Given this list of marker genes RRAD, COMT, AGO2, NCOA3, FIP1L1, SH2D2A, B3GNT2, TOLLIP, AKT2, SRXN1, RRS1, CCL4, ZFPM1, FOS, PROM1, JAK2, STAT5A, CCR1, KCTD12, ATP6V0A2, PSMD11, ST6GALNAC4, ETF1, ELL2, IKZF2, EGR2, ZFP36L1, RDH11, FURIN, RHOQ, TRAF4, ACP3, KLHDC2, AGFG1, PLXND1, ITGB1BP1, OTUD7B, RMDN3, ARHGEF3, COL4A3, GABARAPL1, MTDH, PHLDA1, HCCS, IER2, GGNBP2 (NCBI Gene Id 84160), HMGCR, C9orf85, HNRNPLL, GADD45B, TSPAN5, ZC3H14, PDCD1, E2F5, CMTM3, DNAJB6, IGF1, PRDM1 (PR/SET domain 1), ACTG2 (actin gamma 2, smooth muscle), SLC7A7, RNFT1, NR4A1, NMD3, PPM1A, ITGAV, IL4, IL13, GLI3, TLE3, ZC3H11A, ZC3H12C, ACTR10, KPNA1, CCL1, ROCK2, IRF8, F2R, PIM3, NTMT1 (N-terminal Xaa-Pro-Lys N-methyltransferase 1), MSMO1, TNFSF8, PSMD8, GIMAP4, GCH1, LCP2, SRGN, STS, BCL10, CSF1, SLFN12L, FBXW11, DIP2B, ADRA1B, BTG3, SDCBP, TRAF5, NFKB2, PPP2R2A, CINP, ERF, MAP2K3, SLC4A7, TTC39B, VAPA, KLF13, CCND2, IL10, C1orf43, CHMP4B, TFCP2L1, DNAJC1, CSNK2A2, TGFA, SLC41A1, MYO10, FOSL1, DNAAF5, RXRA (NCBI Gene Id 6256), IL12RB1, ACSL4 (acyl-CoA synthetase long chain family member 4), ATP6V1E1, TMEM68, NFKBIA, NOTCH1, NFATC1, AQP8, TOX4, BCAT1, RPL35, PELI1, NAB2, ADORA2B, ATF3, LAG3, SLC35A4, ZAP70, MRPS2, CUL3, CCL13, FGD3, GOLGA7, GATA3, HSD17B12, CXCL14 (C-X-C motif chemokine ligand 14), ARL6, SPRED2, OSTC, CENPC, ZRSR2, RYR2, BTG1, DUSP2, MOB1B, LTV1, NFKB1 (nuclear factor kappa B subunit 1), TES, UBALD2, METAP1, DDX18, FKBP1A, FYTTD1, EIF2S1, IL5, FHL2, SFXN2, SLC25A19, PTPN1, ATP6V1H, ARID3B, KCNN4, CCL7, ENTR1, BID, IL6, ZNF281, TNF, SEMA7A, TUSC2, VCL, MAPK6, SEPTIN7, USP38, TYMP, FNDC3A, SH3GL3, RNF149, FGF3, EIF1, IQGAP2, DUSP6, H3-4, AQR, RELB, IMP4, IER3, PLA2R1, EGR1, NSMF (NCBI Gene Id 349336), SEC23IP, MAGOH (NCBI Gene Id 4116), here is a description of the gene set: We wanted to test the role of mammalian E proteins E2A and HEB in the development of T cells. Using a conditional deletion system in which these proteins are deleted at the DP stage of T cell development, we compared DP thymocytes deficient for E2A, HEB or both to wild-type thymocytes from publication D'Cruz LM, Knell J, Fujimoto JK, Goldrath AW (PMID 20154672) Genes down-regulated in double positive thymocytes: TCF12 knockout versus TCF3 and TCF12 knockout. species: Homo sapiens Human Gene Set: GSE19923_HEB_KO_VS_HEB_AND_E2A_KO_DP_THYMOCYTE_DN